Given this list of marker genes ACO1, IDH1, here is a description of the gene set: part of: Metabolism of cofactors studied in species Homo sapiens Reactome Pathway: NADPH regeneration The conversion of isocitrate to 2-oxoglutarate (alpha-ketoglutarate) with the concomitant synthesis of NADPH from NADP+ is thought to play a significant role in supplying NADPH for other reactions in both the cytosol and the peroxisome. The activity of H6PD (Hexose-6-phosphate dehydrogenase) is thought to play a role in maintaining NADP+: NADPH balance within the endoplasmic reticulum.